The following is a description of a gene set: species: Homo sapiens Human Gene Set: GOBP_ENDOCARDIAL_CELL_DIFFERENTIATION The process in which a relatively unspecialized cell acquires the specialized structural and/or functional features of an endocardial cell. An endocardial cell is a specialized endothelial cell that makes up the endocardium portion of the heart. The endocardium is the innermost layer of tissue of the heart, and lines the heart chambers., and this is the list of marker genes: SMAD4, SOX18, SOX17 (SRY-box transcription factor 17), NOTCH1, NRG1, ACVR1